Given this list of marker genes AQP11, AQP7, AQP3, AQP9, AQP7B, AQP10, here is a description of the gene set: studied in species Homo sapiens Enables the energy-independent facilitated diffusion of glycerol through a transmembrane aqueous pore or channel. Human Gene Set: GOMF_GLYCEROL_CHANNEL_ACTIVITY